The following is a description of a gene set: species: Homo sapiens Genes predicted to be targets of miRBase v22 microRNA hsa-miR-4328 in miRDB v6.0 with MirTarget v4 prediction scores > 80 (high confidence targets). Human Gene Set: MIR4328 from publication Chen Y, Wang X (PMID 31504780), and this is the list of marker genes: GSAP, PHACTR2, DENND5B (DENN domain containing 5B), DIXDC1, MMS22L, HIVEP2, INPP5B, SYK, PSD, TMBIM6, INPP5F, BIRC6, NFAT5, PALM2AKAP2, KDM1B, MAP1B, CTDSPL2, EPCAM, UPF1, CDC26, PPP1R12A, C5orf24, UBE3C, OSBPL6, LCP2, RGS2, KCNJ15, LGR5, DIPK1B, NAA35, RAP1A, CD164, APC, MATN2, VKORC1L1, SYNPO2, ZNF430, DNAJB2, EEF1A2, GAB1, MTM1, PRCP, ARPC5, KRT10-AS1, KCNJ13 (NCBI Gene Id 619535), LYZL6, KCNH7, HS6ST2, RB1CC1, SLC25A31, LSM14A, TMED5, PDP2, EIF1AX, SAR1B, MED29, PRLR, BICRA, STK39, TMEM178B, CDS1, CEP19, RARA, RBM12, CCL15, TATDN3 (NCBI Gene Id 128387), CMKLR2 (chemerin chemokine-like receptor 2), NIPAL1, WNK3, CTSV, ABRA, KCMF1, TNRC18, RASGRF2, TAOK1, ACVR2A, ICMT, YES1, CISD1, UBE2H, GFPT1, CDC14A, FAM83B, RNF180, NEBL, FBXO22, AKAP12, SNAP25, NSL1, SRGAP3, GRB10, TESK1, SST (NCBI Gene Id 6750), ULK2 (NCBI Gene Id 9706), RBMS3, RNF157, FGF7, AKTIP, SREK1, ASAP2, IDS, TMEM68, SLC30A4, GPM6A, GPC6, ZBTB46, SEPTIN10, PCGF5, ZSWIM1, SLC9A2, LPGAT1, UNC5D, PHTF2, PTPN4, PSIP1, SAMD12, MSI2, MKNK1, RNF216, PRKAA2, MGAT2, NBAS, LUZP4 (leucine zipper protein 4), ZNF737, GNB5, NDST3 (N-deacetylase and N-sulfotransferase 3), KHDC4, POLE3, TNFRSF19, TSC22D2, PEX16, POLD3, TTC39A, RWDD1, SPRED1, HERPUD1, ZBTB41, NECTIN3, ATP8B1, SLC24A2, GALNT3, GABRG2, GOLM1 (golgi membrane protein 1), CHMP2B, PRKCE, FAHD1, ADAM11, SLC26A2, FBXO8, QKI, CRISP3, NPY2R, TIPARP, SLC25A32, SPPL3, PCNX1, ELFN2, LAMB1, RRM2B, RUNX3, SOX11, MAP6, CBFB, SLK, FAT3, SNRNP27, GNAT1, FKBP4, NFATC1, GFI1, GINS1, ZBTB20, DISC1, MYLK4, PACRG, TMEM131, STK17B, RNF168, EVI5, FAM199X, NR2F2, MCFD2, TLL1 (tolloid like 1), H2AZ1, CD302, TMEM181, FGF1, SPG11, PCCA, UTY, HYCC2, FAM76A, EYA3, PAPPA, RPE, CNOT6L, SENP6, MAGOHB, LIN9, LYRM2, BBX, MAP9, SPTLC2, GCLM, ARID1A, MMP24, EGLN1, SLF2, TMOD1, RAB3IP, ESRP2, AFF4, VAPA, GNPTAB, VPS26C, ITGA2, SEC63 (SEC63 homolog, protein translocation regulator), TRIM5, LIN7A, TAF5L (NCBI Gene Id 27097), PWWP2A, ZSCAN26, GEN1, PTEN, YIPF4, SLC17A8, TRIM61, GNAI2, RGS7BP, MAPK13, TENT5A, PAPSS2, C12orf50, LHX3 (NCBI Gene Id 8022), CASK, BTG1, ACTB, MTCL3, PER2, CNOT9, ZFYVE16, PLCL2, SEL1L, SERTAD2 (SERTA domain containing 2), SPRY4, RHAG (Rh associated glycoprotein), SNAP29, ZNF687, RAB27B, ABCD3, SEC24D, KRAS, SGMS2, FMR1, ARAP2, PRUNE1, MTMR7, SUN1, PDE4D, ALG6, NDUFAF4, MINDY2, LRRC58, LOX, GALNT11, PDE7B, BRWD1, OSBPL11, ZYG11B, NSA2, CENPN, KCTD12, CSNK1A1, UCHL5, KCNJ2, LARP4, PHIP, USP16, TNRC6B, FGD6 (NCBI Gene Id 55785), SERINC5, ZNF831, AK2, CTDNEP1, HOXC6, LTB4R, CARF, CLASP2, CCDC34, ZFHX3, C9orf57, TOMM20, BMF, ITPR1, VTI1A, PTGR2, RMND5A, KIRREL2, FIGN, NUDT5, VGLL1 (vestigial like family member 1), SAPCD1, TMEM30B, NAB1, TRABD, ARF6, EPC2, EIF4E, USO1, MBOAT2, SHISA9, ELK3, PYROXD1, KIAA0408, CTAG1A, LHX9, DCUN1D3, PRDM1, KLHL11, B3GNT2, CNKSR2, TBX21, CP, SEPTIN8, PKN2, ERCC8, GMCL1, PPP3CA (protein phosphatase 3 catalytic subunit alpha), EIF2AK3, SEPTIN14, CACNA1C, DPH3, EIF4G2, FOXO3, WDR75, ALCAM, COL27A1, PDE3B, CFAP206, MINDY3, EPM2AIP1, LRRTM3, ADAM22, UNC13C, TACC1, PDGFC, GALT, SP4, GID4, ATP12A, MARCHF10, RECK, FUBP3, UQCC2, ADAM12, TRIM71 (tripartite motif containing 71), GPD2, CSNK1E, MTARC1, PKP1, TOX, PSD3, MGAT4A, SLC30A7, RBM43, TRIM14, RRAS2 (NCBI Gene Id 22800), IMPG2, FBXW7, ZNF559, TNKS2, SHOC2, ZNF514, IFT70A, CCNJL, LY75-CD302, DTNA, VTCN1, SS18, ZNF706, NRG4, CRISPLD1, DCUN1D4, HGF, ARHGEF38, SCAI, ATP10D, ANKRD42, CREBRF, ATE1, EIF1, MECOM (NCBI Gene Id 4197), IRF2BP2, SGIP1, SHROOM4, GLCE, PLA2G12A, ALG10B, FKBP1A, PTGES3L, TPTEP2-CSNK1E, RABGAP1L, ATAD2, BTLA, MED14, ELMO1, LCORL, MAP3K9, BMPR2, HDAC2, SEC61A2, DNAJB9, SLC26A7, NR3C1, RPEL1, NKAIN1, SLITRK5, TARDBP, TFDP2, ZFHX4 (NCBI Gene Id 79776), HYCC1, NUDT16, CAMSAP2, GLIS1, CKAP2L, FCER1G, MTURN, TNIK, SLC4A7, RILPL1, FSTL5, MRTFB, CADM2, LIM2, ACER3, TRPS1, GLIS3, CPNE3, ARL5A, AHR, MCF2L, C1orf21, ITGA8, KCTD1, POGLUT3, RC3H1 (ring finger and CCCH-type domains 1), YAF2, RAB8B, CREB1, C1QTNF7, PAX1, INO80D, SH3D19, TCAF1, WDFY3, OTUD4, CFL2, MARCHF6, GABPB1, KCTD9, NEK4, CMPK2, MBD2, SLC25A21, TMED2 (NCBI Gene Id 10959), DUSP8, GABPA, MAPK10, INSYN1, THPO (NCBI Gene Id 84434), ZFX, LINC01517, LANCL3 (NCBI Gene Id 347404), DNAJC21, PRELID3B, TCTN1, ELL3, PHF20L1, TMEM64, FMN1, CTNND2, ZZZ3, SLC25A33, P2RY1, AMOTL1, VIM, CALU, MNT (NCBI Gene Id 4335), CALHM2, LATS2, CTAG1B, MOGAT2, USP34, ENC1, ABLIM1, GPR12, PEX5 (NCBI Gene Id 5830), DYNC1LI2, CLOCK, FRMD5, ATMIN, KLK2, LACC1, SYTL5 (synaptotagmin like 5), SMAD4, C11orf87, NFIB, KBTBD7, NEDD9, ZEB2, ZIC3, ZNF317, NFASC, UBE2D3, ELP3, ZFP64, DHX33 (DEAH-box helicase 33), RAPGEF6, SLC23A2, CCDC62, EPS8, SPAG16, AQP4, MASTL, OGFOD1, CLU, TRAF6, LTA4H, PSME4, CCNC, SKIL, PAXBP1, MATN4, MTPN, NAP1L5, ANP32E, RBMXL2, PCLO, DUSP6 (dual specificity phosphatase 6), ANAPC7, THOC2, TRAM1, PLPP6, KCNC1, MAST4, KDM6A, SERTM1, MIB1, SLITRK4, TSHR, IRS1, DCP1B, DCUN1D1, SLC39A14, CRADD, NR2C2, ALDOB, SORCS1, TFEC, MBNL3, OSGIN2, RRM2, CAND1, ZBTB2, CDH19, DYRK2, DNAAF9, OPRM1, ILDR2, FXR1, CEP63, SLC6A15, ANKRD12, ZC3H11A, HUS1, THOC1, SLC4A4, PAX3, GIGYF2